The following is a description of a gene set: Catalysis of the reaction: a nucleoside cyclic phosphate + H2O = a nucleoside phosphate. Mouse Gene Set: GOMF_CYCLIC_NUCLEOTIDE_PHOSPHODIESTERASE_ACTIVITY studied in species Mus musculus, and this is the list of marker genes: Pde7a, Pde4a, Pde1b, Pde8a, Adprm, Pde4d, Pde4b, Enpp1, Pde6b, Pde10a, Pde4c, Pde7b, Pde6c, Cnp, Pde5a, Pde6g, Pde6h, Pde1c, Pde2a, Pde1a, Pde11a, Pde3b, Pde8b, Pde3a, Pde6a, Pde6d, Pde9a